Given this list of marker genes SNRK, CSNK1G3, CSNK1A1, TWF1, TRIM33, CDK17, NEK4, DYRK1A, SCYL2, PRP4K, TLK1, MAP4K3, HIPK1, CHUK, SLK, here is a description of the gene set: Genes in the gray cluster of protein kinases distinguishing between luminal A and basal breast cancer subtypes. studied in species Homo sapiens Human Gene Set: FINETTI_BREAST_CANCERS_KINOME_GRAY from publication Finetti P, Cervera N, Charafe-Jauffret E, Chabannon C, Charpin C, Chaffanet M, Jacquemier J, Viens P, Birnbaum D, Bertucci F (PMID 18245477) Breast cancer is a heterogeneous disease made of various molecular subtypes with different prognosis. However, evolution remains difficult to predict within some subtypes, such as luminal A, and treatment is not as adapted as it should be. Refinement of prognostic classification and identification of new therapeutic targets are needed. Using oligonucleotide microarrays, we profiled 227 breast cancers. We focused our analysis on two major breast cancer subtypes with opposite prognosis, luminal A (n = 80) and basal (n = 58), and on genes encoding protein kinases. Whole-kinome expression separated luminal A and basal tumors. The expression (measured by a kinase score) of genes encoding serine/threonine kinases involved in mitosis distinguished two subgroups of luminal A tumors: Aa, of good prognosis and Ab, of poor prognosis. This classification and its prognostic effect were validated in 276 luminal A cases from three independent series profiled across different microarray platforms. The classification outperformed the current prognostic factors in univariate and multivariate analyses in both training and validation sets. The luminal Ab subgroup, characterized by high mitotic activity compared with luminal Aa tumors, displayed clinical characteristics and a kinase score intermediate between the luminal Aa subgroup and the luminal B subtype, suggesting a continuum in luminal tumors. Some of the mitotic kinases of the signature represent therapeutic targets under investigation. The identification of luminal A cases of poor prognosis should help select appropriate treatment, whereas the identification of a relevant kinase set provides potential targets.